The following is a description of a gene set: Genes down-regulated in HMC-1 (mast leukemia) cells: incubated with the peptide ALL1 and then treated with Cl-IB-MECA versus stimulation by T cell membranes. species: Homo sapiens from publication Baram D, Dekel O, Mekori YA, Sagi-Eisenberg R (PMID 20190146) Human Gene Set: GSE19888_ADENOSINE_A3R_INH_PRETREAT_AND_ACT_BY_A3R_VS_TCELL_MEMBRANES_ACT_MAST_CELL_DN We demonstrate that the G protein Gi3 is the cellular target of the adenosine A3 receptor (A3R). By using a cell permeable peptide comprising the C-terminal end of Gαi3 fused to an importation sequence (ALL1) as a selective inhibitor of Gi3 signaling, we show that by coupling to Gi3, the A3R stimulates multiple signaling pathways in human mast cells, leading to upregulation of cytokines, chemokines and growth factors.Following contact with activated T cell membranes, endogenous adenosine binds to and activates the A3R, resulting in Gi3-mediated signaling. Specifically, the majority of ERK1/2 signaling initiated by contact with activated T cell membranes, is mediated by Gi3, giving rise to ALL1-inhibitable cellular responses. These results unveil the physiological GPCR that couples to Gi3 and establish the important role played by this G-protein in inflammatory conditions that involve adenosine-activated mast cells. We used microarrays to detail the effect of ALL1 on gene expression of HMC-1 cells activated directly by the A3 receptor, or by contact with activated T cell membranes., and this is the list of marker genes: MINDY1, FASTKD1, SLC25A51, GFER (growth factor, augmenter of liver regeneration), TYSND1, MEF2D, ARMCX1, NF2, CAMK2G, DDB2, C12orf43, ALDH18A1, PLPP2, GIGYF2, IKBIP, EIF2AK3, S100A8, CNKSR3, ESPL1, TBX1, NAPEPLD, RNF26, TBC1D10B, PCSK7, SLC16A7, LMAN1, CHST11, DUS3L, ATRNL1, SFT2D3, EXOC8, SEC16B, APMAP, RAB4A, CHCHD5, MSANTD3, TOM1, ANAPC16, RBM33, POFUT2, DECR1 (NCBI Gene Id 1666), ENKD1, GPD1L, C5orf34, LENG9, ANKRD50, SUPT5H, REEP6, ZMYND8, FECH, HCFC1R1, PDRG1, HELZ, CHD8, CASC3, IGF1, PPFIA3, PFKFB1, HMG20A, GADL1, PEBP1, PARP16, TRIR, TDP2, ECI2, TRIP6 (NCBI Gene Id 96624), PABPN1, SMIM20, SSH1, KLHL2, TAL1, FSCN1, FZD2, GPR137B, DEDD2, RAB34, KATNIP, TMEM131L (transmembrane 131 like), PIERCE2, CDR2, ADRM1, FAM114A2, PAQR4, TMEM42, POMT1, UBE2J1, RCAN3, NEPRO, S100A9, TRIM68, PITHD1, PHLDA1, ZNF513, SNHG32, CARM1, DUBR, KRTCAP2, WDR33, ZMYND19, DOLK, COX6A1, SLC26A7, ZNF32, OST4, SUFU, HMGB3, POLR2F, TXNDC15, FAM193B, MRTFB, XPC, HDAC6, COL6A5, TOR2A, KRBA1, SETDB1, GPAM, COIL, FBXL12, TTC4, DELE1, TMUB2, AP1G2, RAB40C, ACP6 (NCBI Gene Id 95651), ERCC4, H2AX, TFIP11, VSIR, PDCD4, PDZRN4, CAD (NCBI Gene Id 790), ALG10, OTULIN, LRRC57, NDUFA1, PDAP1, SCP2, LRP6, CYP2D6, STIMATE, ANKMY2, GRB7, SH3KBP1, E4F1, STX5, EEF1AKMT2, RFNG, USP30, CCDC97, CHMP6, KCTD2, TFAP2E, COL18A1, PRPF31, ABR, RAPGEFL1, SH3BGRL3, NELFB, KLF10, RPL36, NOTCH4, PRPS2, FAM185A, NDRG4, ELP5 (NCBI Gene Id 23587), REEP5, SNHG8, LURAP1L, PIGL, GASK1B, MOCS3, BSCL2, PHTF1, MMP9, CCDC91, EFR3A, ARRDC2, ANP32B, TCTA, EXOSC4, PNKD, TLE3, ANKRD16, RAD51D, RPL30, MIR99AHG, ETV5, MXD4 (NCBI Gene Id 10608), RPL28, SLC39A11, KAZALD1, TUBGCP2, GSTO1, SLC35G1, SOX18, TRIB2, HSPA12B, RPL23A